The following is a description of a gene set: studied in species Homo sapiens Reactome Pathway: SUMOylation of immune response proteins part of: SUMO E3 ligases SUMOylate target proteins NF-kappaB transcription factors are sequestered in the cytosol due to their association with IkappaB. During activation of NF-kappaB, IKK phosphorylates IkappaB, releasing NF-kappaB for importation into the nucleus. NF-kappaB transcription factors, the NFKBIA component of IkappaB, and subunits of the IKK complex can be SUMOylated. SUMOylations of IkappaB, NFKBIA, and RELA inhibit NF-kappaB signaling; SUMOylation of NFKB2 is required for proteolytic processing., and this is the list of marker genes: SUMO3, TOPORS, IKBKG, EIF2AK2, RELA, PIAS4, NFKBIA, SUMO1, IKBKE, NFKB2, UBE2I, PIAS3